The following is a description of a gene set: Ambiguous genitalia Human Gene Set: HP_AMBIGUOUS_GENITALIA species: Homo sapiens A genital phenotype that is not clearly assignable to a single gender. Ambiguous genitalia can be evaluated using the Prader scale: Prader 0: Normal female external genitalia. Prader 1: Female external genitalia with clitoromegaly. Prader 2: Clitoromegaly with partial labial fusion forming a funnel-shaped urogenital sinus. Prader 3: Increased phallic enlargement. Complete labioscrotal fusion forming a urogenital sinus with a single opening. Prader 4: Complete scrotal fusion with urogenital opening at the base or on the shaft of the phallus. Prader 5: Normal male external genitalia. The diagnosis of ambiguous genitalia is made for Prader 1-4., and this is the list of marker genes: IGF2, WWOX, FGF8, FRAS1, CHD4, IRF6, CILK1, CSPP1, VAMP7, TMEM107, NR2F2, AKR1C4, FSHR, MAP3K1, COX7B, FZD2, SPIDR, GAS1, TOE1, IFT80, DHCR24, NR0B1, RIPK4 (NCBI Gene Id 54101), TMEM216, NDUFB11 (NADH:ubiquinone oxidoreductase subunit B11), HSD3B2, MRPS22, TCTN3 (tectonic family member 3), MINPP1, TMEM237, PAX6, BMP15, CDON, SUFU (SUFU negative regulator of hedgehog signaling), DYNC2I2 (dynein 2 intermediate chain 2), CKAP2L, ZFPM2, RPGRIP1L, CRIPTO, CYP17A1, TWIST2, ATRX (ATRX chromatin remodeler), SRY, B9D2, FDXR, TGIF1, POR, PBX1, SIX3, NR5A1, HCCS, TRIP13, TCTN1, AR, CYP19A1, CEP41, BDNF, HSD17B3, WT1, CEP290, VANGL1, BUB1B, AKR1C2, CC2D2A, ATP6V1B2, TMEM67, IFT81, TSPYL1, FOXH1 (forkhead box H1), CTU2, CEP57, ARX, FREM2, NODAL, TRAIP, DYNC2I1, TXNDC15, BNC1, GATA4, BUB3, DHCR7, CYP11B1, ZIC2, SOX3, ZNF699, SC5D, HOXD13, GLI2, POLR3H (RNA polymerase III subunit H), RSPO1, NUP107, CYB5A, GLI3, SRD5A2, PSMC3IP, FUZ, B9D1, ZMYM3, MSH4, TMEM231 (transmembrane protein 231), CEP120, TCTN2, PTCH1, WNT4, DYNC2H1, DLL1, TBX15, NEK1, MYRF, SHH, DHX37, ZSWIM7, SOX9, DISP1, GRIP1, WDR35, MKS1, FGFR1, TNXB, TBC1D24, NR3C1, CYP11A1, RPGRIP1, BUB1 (NCBI Gene Id 699)